The following is a description of a gene set: from publication Yevshin I, Sharipov R, Kolmykov S, Kondrakhin Y, Kolpakov F (PMID 30445619) Human Gene Set: LHX3_TARGET_GENES species: Homo sapiens Genes containing one or more binding sites for (LHX3) in their promoter regions (TSS -1000,+100 bp) as identified by GTRD version 20.06 ChIP-seq harmonization., and this is the list of marker genes: H3-3A, PAXIP1-AS2, SLC7A11, SNORD118, RBBP8, TRIM7, HOXA9, H3C12, MSL2, PCDH1, ENC1, RNY4, HOXB8, TOP2A, H1-4, H2AC4, CRAMP1, UNC45A, ZFP62, H3C6, H2BC5, H2BC15, F12, H3C1, HMGN4, H2BC6, H2AC17, H2BC9, LURAP1L-AS1, GRK6, H2BC17, TMEM62, ANXA2R-OT1, H2AC15, IFT140, SETD9, TNRC18